The following is a description of a gene set: Erythrocytes take up oxygen and release carbon dioxide species: Homo sapiens Human Gene Set: REACTOME_ERYTHROCYTES_TAKE_UP_OXYGEN_AND_RELEASE_CARBON_DIOXIDE, and this is the list of marker genes: HBA1, CA1, CA4, CA2, HBA2, SLC4A1, HBB, RHAG, AQP1